The following is a description of a gene set: Cellular senescence plays an important role in normal aging, as well as in age-related diseases. Impaired cellular senescence contributes to malignant transformation and cancer development. Presence of an excessive number of senescent cells that are not cleared by the immune system, however, promotes tissue inflammation and creates a microenvironment suitable for growth of neighboring malignant cells. Besides cancer, senescence is also involved in atherosclerosis, osteoarthritis and diabetes.<br><br>Evasion of oncogene-induced senescence, at least in cell culture, can occur due to loss-of-function (LOF) mutation in the CDKN2A gene product p16INK4A that acts as a cyclin-dependent kinase inhibitor. LOF mutations in the CDKN2A gene that affect its other protein product, p14ARF, involved in stabilization of TP53 protein (p53), can contribute to evasion of oncogene-induced senescence.<br><br>LOF mutations in p16INK4A and p14ARF also contribute to evasion of oxidative stress-induced senescence. Reactome Pathway: Diseases of Cellular Senescence part of: Diseases of cellular response to stress species: Homo sapiens, and this is the list of marker genes: CDK6, CDK4, CDKN2A